Given this list of marker genes CLCN6 (NCBI Gene Id 1185), LMBRD2, MPDZ, COG8, LMNB1 (NCBI Gene Id 445266), SLC38A8, CDC42BPB, APC, DPP6, PPP2R5D, here is a description of the gene set: Alternating esotropia Human Gene Set: HP_ALTERNATING_ESOTROPIA Esotropia in which either eye may be used for fixation. studied in species Homo sapiens